Given this list of marker genes Gnaz, Htr1f, Htr2b, Gnai1, Htr5a, Htr1d, Htr5b, Htr4, Htr6, Htr1a, Htr2c, Htr2a, Gnao1, Plcb3, Htr7, Htr1b, here is a description of the gene set: The series of molecular signals generated as a consequence of a G protein-coupled serotonin receptor binding to one of its physiological ligands. Mouse Gene Set: GOBP_G_PROTEIN_COUPLED_SEROTONIN_RECEPTOR_SIGNALING_PATHWAY species: Mus musculus